Given this list of marker genes H2-T23, Btk (NCBI Gene Id 215271), Cd24a, C3, Ccr7, Fcer1a, Ighg1, Fcer1g, Cnr1, Kars1, Fcgr1, Ighg2b, Lta, Cd28, Park7, Fcgr3, Zp3, Tnf, Cd81, here is a description of the gene set: Any process that activates or increases the frequency, rate, or extent of an inflammatory response to an antigenic stimulus. studied in species Mus musculus Mouse Gene Set: GOBP_POSITIVE_REGULATION_OF_INFLAMMATORY_RESPONSE_TO_ANTIGENIC_STIMULUS